The following is a description of a gene set: Genes predicted to be targets of miRBase v22 microRNA hsa-miR-4280 in miRDB v6.0 with MirTarget v4 prediction scores > 80 (high confidence targets). species: Homo sapiens Human Gene Set: MIR4280 from publication Chen Y, Wang X (PMID 31504780), and this is the list of marker genes: INPP4A, VSTM2B, CEP192, ITPRID2, GABRB2, SLC37A3, TLNRD1, ZBTB41, DCAF6 (DDB1 and CUL4 associated factor 6), FBXO21, RERE, RHEB, SP110, FLRT2, SCAF8, UBXN2A (NCBI Gene Id 165324), ATP4B, HIPK3, NMBR, CDC73, TNFRSF1A, KDM5C, RHOBTB3, RAB12, KCNJ8, APBB2, POLR3GL (RNA polymerase III subunit GL), SLC39A6, FMNL2, FAM222B, CDC14A, FRAT1, TSHR, DOCK7, TNRC6C, ADAMTS3, LSMEM2, TMEM59, C2CD2, CDK4, CAPN6, FNIP1, ZNF248, SGK3, CCDC62, DIRC1, PFKM, BMAL2, LRRTM3